Given this list of marker genes STX3, ALOX5AP, TMEM175, GPR31, PPARG, S100A8 (S100 calcium binding protein A8), FABP3, S100A9, here is a description of the gene set: Binding to icosatetraenoic acid, any straight-chain fatty acid with twenty carbon atoms and four double bonds per molecule. Human Gene Set: GOMF_ICOSATETRAENOIC_ACID_BINDING studied in species Homo sapiens